The following is a description of a gene set: species: Homo sapiens from publication Korkola JE, Houldsworth J, Dobrzynski D, Olshen AB, Reuter VE, Bosl GJ, Chaganti RS (PMID 15870693) Genes predicting the yolk sac tumor (YS) subtype of nonseminomatous male germ cell tumors (NSGCT). Human Gene Set: KORKOLA_YOLK_SAC_TUMOR Male adult germ cell tumors (GCTs) comprise two major histologic groups: seminomas and nonseminomas. Nonseminomatous GCTs (NSGCTs) can be further divided into embryonal carcinoma (EC), teratoma (T), yolk sac tumor (YS), and choriocarcinoma (CC) on the basis of the lineage differentiation that they exhibit. NSGCTs frequently present as mixed tumors consisting of two or more histological subtypes, often limiting correlative studies of clinical and molecular features to histology. We sought to develop a molecular classifier that could predict the predominant histologic subtype within mixed NSGCT tumor samples. The expression profiles of 84 NSGCTs (42 pure and 42 mixed) and normal age-matched testes were obtained using Affymetrix microarrays. Using prediction analysis for microarrays, we identified 146 transcripts that classified the histology of pure NSGCTs samples with 93% accuracy. When applied to mixed NSGCTs, the classifier predicted a histology that was consistent with one of the reported components in 93% of cases. Among the predictive transcripts were CGB (high in CC), LCN2 (high in T), BMP2 (high in YS), and POU5F1 (high in EC). Thus, the expression-based classifier accurately assigned a single predominant histology to mixed NSGCTs, and identified transcripts differentially expressed between histologic components with relevance to NSGCT differentiation., and this is the list of marker genes: SRGN, PTPN13, CDH2, SLC2A3, MOK, SLC5A9, APOA2, CYP26A1, PRTG, PLXNA2, NEK2, SHISA2, CCKBR, PDZK1, FLRT3, HAS2, EOMES, APOA1, OTX2, COCH, TRIM22, VTN, C5, FZD5, C1R, MIR1915HG, ERBB4, HMGA2, SMARCA2, C1S, BMP2, CEP70, COL4A6, FYB2, EHHADH, CEBPD, B4GALT4, CST4, HACD1, CST1, PCDH7, IPO5P1, MDK, TMT1A, LINC00261, LRRN1, P3H2, PCDH10 (NCBI Gene Id 57575), TTN, FOXA2, CTSV, MGP, SALL1, RASSF10, DCN, LUM, NMI, FRAS1 (Fraser extracellular matrix complex subunit 1), NRG1, SOX17, LINC02387, VANGL1, ROR2, CHST13, RAB17